Given this list of marker genes Ptpn6, Plcg2, Grb2, Stim1, Syk (spleen tyrosine kinase), Cd79b, Cd19, Vav1, Dapp1, Trpc1, Pik3ap1, Cd79a, Igll1, Blnk, here is a description of the gene set: Reactome Pathway: Antigen activates B Cell Receptor (BCR) leading to generation of second messengers part of: Signaling by the B Cell Receptor (BCR) This event has been computationally inferred from an event that has been demonstrated in another species.<p>The inference is based on the homology mapping from PANTHER. Briefly, reactions for which all involved PhysicalEntities (in input, output and catalyst) have a mapped orthologue/paralogue (for complexes at least 75% of components must have a mapping) are inferred to the other species. electronically inferred by orthology from the curated human pathway species: Mus musculus